Given this list of marker genes PCSK1N, RASD1, C6orf58, MEG3, CPE, MS4A8, SCG2, GC, PAX6, DDC, CACNA1A, SCG5, here is a description of the gene set: from publication Busslinger GA, Weusten BLA, Bogte A, Begthel H, Brosens LAA, Clevers H (PMID 33691112) studied in species Homo sapiens Human Gene Set: BUSSLINGER_GASTRIC_ANTRAL_ECS